Given this list of marker genes ZNF197, DMTN, BEX1, PCLO, FBXL16, CELF5, RAB3A, THRB, FADS3, ZC2HC1A, ACTR3B, PPFIBP1, ASPSCR1, FOXP1, JAG2, CELSR2, CELF3, ENTREP2, TTC9B, LRP12 (LDL receptor related protein 12), TAB1, LRRN3, TUBB2B (NCBI Gene Id 347733), KPNB1, KIAA0319, NRXN2 (NCBI Gene Id 9379), NGRN, STUM, SASH1, PTPRK, RAP1GDS1, NLN, DCLK2 (doublecortin like kinase 2), RGS11 (NCBI Gene Id 8786), NAV1, DLG3, AMER2, MIR124-1HG, NPDC1, SDK2, CCBE1, TCEA2, SRCIN1, CBLN2, ANKRD13B, NUP93, SRRM4, GAP43, CNR1, NCAM1, SNCB, PIP4K2A (phosphatidylinositol-5-phosphate 4-kinase type 2 alpha), NLK, FXR2, MOK, C1orf216, PPP1R14C, LINC01102, FAM81A, NPY, PIK3R2, PHF24, NSG2 (neuronal vesicle trafficking associated 2), TUBB4A, TMEM132A, PTPRO, NDRG1, HMGCR, CACNA1C, CAMK2B, FCHO1, CCDC184, RBM24, SPTAN1, GRP, SYP, CRMP1, APBB1, NFIX, DPYSL2, CYFIP2, LRRC49, MGLL, SPTBN1, AMPD2 (NCBI Gene Id 271), RIPOR2, TENM4, EPM2AIP1, PPP2R2D, GPR12, DOK5, ACAP3, ALCAM, ADCY1, APC2, ZNF614, SEZ6L2, C12orf57, DLX2, CDC42EP4, CDC42EP3, GOLGA8A, MAPRE3, LMO4, PPFIA2, TUBB3, CAP2 (NCBI Gene Id 10486), PDIA2 (protein disulfide isomerase family A member 2), SOX4, RRAS2, MAPK10, SYBU, STMN2, NKAIN2, AK1 (NCBI Gene Id 203), TNKS2, ZNF324, KIF3A, DPF1, MFSD10, JPH4, SATB2, RELA (RELA proto-oncogene, NF-kB subunit), GPC1, PCBP4, TPPP, CSRP2, ATXN2, CERK, B4GAT1 (beta-1,4-glucuronyltransferase 1), PRKAR1B, NT5C3B, GUCY1A2, C11orf87, NCS1, CLVS2, SYT5, PHPT1, PLXNA4, HIP1R, NRXN1, NELL2, CEP126, USP46, MAPK8IP1, PRKCB, ATXN7L3B, MT3, GPSM1, SOBP, PAFAH1B2, NFIA, CTIF (cap binding complex dependent translation initiation factor), GAREM2, SYNGR3, PCDH11X, GTF2IRD1, SLN, SLC39A3, C2orf69, LIMCH1, LINC00667, RAB15, PRKAR2B, CELF4, STMN3, CACNA1E, AMPH, TSC2, ZBTB18, HSF2, EPHA5, POU3F1, HAGHL, DNM1, MYO16, DGKE, THRA, ADGRB2, FZD3, TRIM67, TCF4, RNF112, DAAM1, SNX32, GNAL, KIF1A (kinesin family member 1A), LINC00342, CXXC4, ATP6V0E2, KDM5B, TUBB2A, ADD2, NAP1L3, ARPP21, PGM2L1, WDR59 (WD repeat domain 59), ANK2, FUBP1, ANK3, SCG5, ENSG00000286190, TANC2, NEFM, CEP15 (centrosomal protein 15), CRIP2, DAB2IP, FGF13, STARD10, ATCAY, SUZ12P1, STX1A, LIMS2, NEFL, KNDC1, FAM110B, ARK2C, RSPRY1, TENM2, PKD1, OPTN, FBXO3, TDRP, SGSM2, TARS3 (NCBI Gene Id 123283), NCOA1, RAB9B, ABLIM1, PXK, IMPDH1, KCNA6, EBF4 (EBF family member 4), SAMD4B, RAP1GAP2, KLF12, DBNDD1, PPP5C, AGPAT5, AKT3 (NCBI Gene Id 26068), DPYSL3, LPAR2, AGTPBP1, ZFR2, SRM, GNG4, VSTM2L, RUNX1T1, HMOX2, PNMA2, TMEM151B, TXNL4A, PHACTR3, NCDN, CHGB (chromogranin B), PRKAA2, FBXW7, FLRT2, MBTPS1, RIMBP2, FGF12, MAP4, CARMIL3, WDR47, RIT2, CARM1, FAM229B, SEMA3C, MAP1A, OPCML, ELAVL3, CSMD1, CHRNA4, B4GALNT4, PNMA3, REEP2, SNAP91, DNM3, LSAMP, EFNA2, NUDCD3, RNF40, MDGA1, SYNGAP1, POLR3A, FABP3 (NCBI Gene Id 337956), RAMP3, FKBP1B, NSG1, TMEFF2, UBXN7, MVD, GNG8, TRIM2, MEG3, CPLX1, CES2, SCD5, INA, KIAA1549L, MAP6, RBM4B, RFNG, FAM184A, KCNH7-AS1, SHANK2, NTRK2, STMN4, CDH10, UCHL1, PLXNA1, BAALC (BAALC binder of MAP3K1 and KLF4), KIF1B, KRT19, BOK, MORN4, NFASC, CRACD (NCBI Gene Id 57482), DCLK1, NBEA, TUBA1A, SSBP3, GDA, PI4KAP2, CELF2-AS2, ATP1B2, MPPED1 (metallophosphoesterase domain containing 1), RNF220, CSMD3, BHLHE22, ADAM22, ZFTA, SULT4A1, ARL4C, ANKRD16, SYT4, SHISA7, PJA1, SYT3, CSRNP3 (NCBI Gene Id 80034), BCL11A, CACFD1, DPYSL4, EEF1A2, FAT3, C8orf33, GRIA3, PREPL, UBE2QL1, TACC2, SDC3, STXBP1, FMN2, LGI4, NEO1, ABCA2, AKAP7, RALGPS1, NIPSNAP3A, TMEM121B, CADM1, PPP3CB, SCN2A, NETO2, MOAP1, FXYD7, ENO2, DDX51, TSPOAP1, ARL8A, CDH2, SHC2, SH3PXD2A, NECAB1, RFPL1S, PTPN13, PCSK1N, GLRA2, CYP27C1, GPRIN1, CSMD2, TCEAL5, DTX1 (deltex E3 ubiquitin ligase 1), CTXN1, HPCAL4, RNF157, DCX, ZSCAN29, IVNS1ABP, LSM14B, TNRC6C, MLLT3, TCP1, MAST4, GRIN1, CENPV, PRXL2B, UQCC6, CPNE6, GNAO1, OPA1, CAMK2N1, USP32P2, SV2A, IGSF21, GAD1, DYNC1I1, TRIM44, PRRT2, WASF1, MAST1, TLE5, CACNG8, CYRIA, LY6H, SEPTIN3, NEUROD6, AGAP3, EXD3, MYH10, AP3B2, NFIB, GCSH, LRRC4C, KRT31, NCAN, SMARCA2, FYN, SEPTIN4, KIF3C, MATK, MAP1B, KIFAP3, CACNB3, DMWD, PTP4A3, SERPINI1, NDRG4, FUT9 (NCBI Gene Id 10690), GNAZ, JPH3, ARHGAP33, KDM4B, ARID3B, VSTM2B, IRS2, MARCKSL1, SERP2, VAV2, FABP7, KCNA3, EIF4EBP2, ACOT7, ACKR1, RIC3, KIF21B, RNU6-2, PTPN5, LRP6, BCYRN1, WWC1, CSDC2, LRRC7, COMTD1, PALS2, KCNB1, PPHLN1, BAIAP2, BMERB1, MAPT, ACTN2, GUCY1A1, CLIC4, EPHA10 (EPH receptor A10), STK25, BEX2, CACNA1A, AGPAT4, ENHO, SDK1, TCEAL2, THY1, CACNA1B, CAMKV, SLIT1, AKT2, PFN2, PENK, MYT1L, here is a description of the gene set: from publication Zhong S, Zhang S, Fan X, Wu Q, Yan L, Dong J, Zhang H, Li L, Sun L, Pan N, Xu X, Tang F, Zhang J, Qiao J, Wang X (PMID 29539641) studied in species Homo sapiens Human Gene Set: ZHONG_PFC_C3_MICROGLIA